The following is a description of a gene set: Human Gene Set: GOMF_HYALURONONGLUCOSAMINIDASE_ACTIVITY Catalysis of the random hydrolysis of (1->4) linkages between N-acetyl-beta-D-glucosamine and D-glucuronate residues in hyaluronate. species: Homo sapiens, and this is the list of marker genes: HYAL3, HYAL2, CEMIP, HYAL4, OGA, HYAL1, CEMIP2, SPAM1